The following is a description of a gene set: A reduced concentration of copper in the blood. Decreased circulating copper concentration studied in species Homo sapiens Human Gene Set: HP_DECREASED_CIRCULATING_COPPER_CONCENTRATION, and this is the list of marker genes: ATP6AP1, TMEM199 (NCBI Gene Id 170473), AP1S1, CP, ATP7A, SLC33A1, COG2, AP1B1